The following is a description of a gene set: studied in species Homo sapiens Genes up-regulated in comparison of dendritic cells (DC) stimulated with R848 at 2 h versus DCs stimulated with LPS (TLR4 agonist) at 8 h. Toll like receptors (TLRs) sense microbial products and initiate adaptive immune responses by activating dendritic cells (DCs). Since pathogens may contain several agonists we asked whether different TLRs may synergize in DC activation. We report that in human and mouse DC TLR3 or TLR4 potently synergize with TLR7, TLR8 or TLR9 in the induction of selected cytokine genes. Upon synergistic stimulation, IL-12, IL-23 and Delta-4 are induced at levels 50-100 fold higher than those induced by optimal concentrations of single agonists, leading to enhanced and sustained TH1 polarizing capacity. Using microarray analysis we show that only 1.5% of the transcripts induced by single TLR agonists are synergistically regulated by combinations of TLR4 and TLR8 agonists. These results identify a combinatorial code by which DCs discriminate pathogens and provide (suggest) a rationale to design adjuvants for TH1 responses. Series_overall_design: 3 untreated, 3 treated with LPS at 2h, 3 treated with LPS at 8h, 3 treated with R848 at 2h, 3 treated with R848 at 8h, 3 treated with LPS + R848 at 2h, 3 treated with LPS + R848 at 8h Human Gene Set: GSE2706_2H_VS_8H_R848_AND_LPS_STIM_DC_UP from publication Napolitani G, Rinaldi A, Bertoni F, Sallusto F, Lanzavecchia A (PMID 15995707), and this is the list of marker genes: SIGLEC17P (sialic acid binding Ig like lectin 17, pseudogene), IGFLR1, GSTT1, RASAL1, HEMK1, CD1C, AIFM1, GLRX5, SPATA17, DPY19L3, CMTM8, GNAQ, TMTC4, GLIPR2, NMNAT3 (nicotinamide nucleotide adenylyltransferase 3), TPST2, PLAU, TBC1D10C, PMVK, RRAS, COPS6 (NCBI Gene Id 10980), NCKAP1L (NCK associated protein 1 like), TMT1A, UQCRC1, TACC3, SNX29, ITFG1, DOCK2, ARL6IP4, CAMKMT, PYCARD, ATP8B4, CEP57, AQP3, CLEC10A, AP2S1, DIAPH1, EIF2D, CTSO, ATM, PCYOX1, LINC01126, FAM210B, ANKRD50, TM6SF1, RNF5, CCDC14, MYO1F, PDZD11, CHN2, MPG, RPL3, RAMP1, MSI2, ANKRD44, RIN2, SLC25A35, PIH1D1, STX10, DPY30, BTN2A2, CYC1, TWF2, NAA40, CERK, HEBP2, HAGH, WDR54, HCAR3 (hydroxycarboxylic acid receptor 3), CCDC28A, NDUFS7, NRGN, CD33, NNT, PRKACB, GALC, TLR2, SLC25A5, LPCAT4, OR2F2, PDHB, CBFB, RPS6, EEF1G (NCBI Gene Id 1937), CPB2, MIF4GD, PPP1R7 (protein phosphatase 1 regulatory subunit 7), TTC3, CRTAP, ASPSCR1, ATP5MC2, TMEM161A, RFC2, KIAA0930, LCP2, PDK3, GSTK1, C2orf15, NDUFA12, APEH, RPS4Y1, IL17RA, ALOX15, MAT2A, HACD4, RGS18, FAM111A, LNPK, ZFP36L2, ACAT1, WDFY4, NDUFB10, CTSH, SPOPL (NCBI Gene Id 339745), CBX2, SLC41A3, AK2, CHCHD7, PRCP, KLF7, CDK20, ACSM3, TRAP1, MRPL48, C1orf162, ELMOD2, NDUFB7, FA2H, MGST2, SGK1, BANF1, VSIR, RTN3, GALNT16, HSD3B7, HAUS4, MARCHF8, QPRT, ZNF641, NDUFAF6, ABHD12, IL13RA1, FCER2, IFIT2, RAB34, CPNE3, PTTG1IP, EGR1, CACYBP, NDRG2, PTGER2, CPT1A (NCBI Gene Id 1374), ANTKMT, LTA4H (leukotriene A4 hydrolase), PTGR1, HVCN1, CFAP74, PPM1J, RABGEF1, AUH, ICMT (NCBI Gene Id 57087), EPRS1, CCT6B, PIGN (phosphatidylinositol glycan anchor biosynthesis class N), HACD3 (NCBI Gene Id 95112), FARP1, LSM7, DHPS, TMX4, FLT3LG, GRK3, TMEM59 (NCBI Gene Id 9528), COX11, ADAM10, GRAMD4, TMEM154, ADK, SGCB, MICAL2 (NCBI Gene Id 9645), ARHGEF6, PIPOX, ERBIN, ATXN8OS, ECHDC1, PHYH, ALAD, SLC27A4 (solute carrier family 27 member 4), LSM4, BLTP2, HS2ST1, MAP2K6, RPL10A, NCAPH, MAD2L2, NIPAL2, HSD17B10, SLC8B1, HAUS7